Given this list of marker genes TUBA1C, KIF5C, TUBB4A, TUBB1, KIF5B, TUBA4A, TUBB3, TUBA3E, KIF5A, TUBB2A, TUBB6, TUBA3D, KLC1, KLC3, KLC2, TUBB4B, KLC4, TUBB2B, TUBA1A, TUBB, TUBA1B, TUBA8, TUBA3C, TUBB8, here is a description of the gene set: species: Homo sapiens Anterograde axonal transport. Pathway ID: N00978. Pathway type: Reference. Pathway class: nt06460 Alzheimer disease. Pathway Definition from KEGG: (KIF5+KLC) == (TUBA+TUBB) Human Gene Set: KEGG_MEDICUS_REFERENCE_ANTEROGRADE_AXONAL_TRANSPORT